The following is a description of a gene set: Human Gene Set: WP_CONVERSION_OF_ANGIOTENSINOGEN_TO_ANGIOTENSIN_II studied in species Homo sapiens Conversion of angiotensinogen to angiotensin II, and this is the list of marker genes: REN, CMA1, CTSD, CTSG, ACE